The following is a description of a gene set: studied in species Mus musculus Mouse Gene Set: REACTOME_BASE_EXCISION_REPAIR Base Excision Repair, and this is the list of marker genes: H2bc22, Apex1, H2bc6, Pcna, H2bc1, Pold1 (polymerase (DNA directed), delta 1, catalytic subunit), H2ac7, Rfc3, Rpa1 (replication protein A1), Pnkp, H2bc8, H2bc23, H2ac15, Pot1a, Polb, H2bc15, H2ab1, H2ac10, Pold2, H3f4, H4c3, Pole3, Pole, H2ac23, H2ab3, Parp1, Tdg, H2ac20, Acd (adrenocortical dysplasia), H4c9, H2bc7 (H2B clustered histone 7), Terf2ip, Ogg1, Rfc5, Nthl1, Rpa2, Terf2, H2ac22, Neil1, Lig1, Pold3, Pole4, H4c14, Mpg, H2bc4, Xrcc1, H4c6, H4c4, H2aj, H4c2, H2az2, Rfc1, H4c1, H4c18, H4c12, H2bc11, H2ac4, Neil3, Fen1, Terf1, H2ac24, H2bc13, H2ac12, Mbd4, H2bc14, H2ac11, H2bc26, Smug1, H2ax, H2ac13, Neil2, H2bc9, Rpa3, Rfc4, H2ab2, H4c16, Pold4, H2bc24, H2ac6, Pole2, Adprs, Parg, Parp2, H2ac8, Rfc2, H2ac18, H4c17, H2ac19, H4c8 (NCBI Gene Id 69386), H2bc21, Lig3, H4c11, Mutyh, H2bc12, H2bc3, Ung